The following is a description of a gene set: Genes negatively differentially expressed in cell type: CD8+ T cell upon treatment with cytokine: IL-18 in mouse lymph nodes in vivo. Mouse Gene Set: CUI_T_CELL_CD8_IL18_RESPONSE_DN studied in species Mus musculus from publication Cui A, Huang T, Li S, Ma A, Pérez JL, Sander C, Keskin DB, Wu CJ, Fraenkel E, Hacohen N (PMID 38057668) Cytokines mediate cell-cell communication in the immune system and represent important therapeutic targets. A myriad of studies have highlighted their central role in immune function, yet we lack a global view of the cellular responses of each immune cell type to each cytokine. To address this gap, the authors created the Immune Dictionary, a compendium of single-cell transcriptomic profiles of more than 17 immune cell types in response to each of 86 cytokines (>1,400 cytokine-cell type combinations) in mouse lymph nodes in vivo. A cytokine-centric view of the dictionary revealed that most cytokines induce highly cell-type-specific responses. For example, the inflammatory cytokine interleukin-1β induces distinct gene programmes in almost every cell type. A cell-type-centric view of the dictionary identified more than 66 cytokine-driven cellular polarization states across immune cell types, including previously uncharacterized states such as an interleukin-18-induced polyfunctional natural killer cell state., and this is the list of marker genes: Entrep3, Pdcd4, Srgn, Bcl2, Hmgb2, Tent5a, Cd53, Ssh2, Arl4c, Celf2, Cotl1, S1pr1, Pitpnc1, Stim1, Klhl6, Tsc22d3, Ankrd44, Slamf6 (NCBI Gene Id 80894), Sidt1 (NCBI Gene Id 385649), Btg2, Kmt2e, Tecpr1, Klf3, Tagln2, Ctsw, Vim, Add3, Zfp36l2, Pnrc1, Ets1, Gpr183, Lsp1, Txk, Kif21b, Esyt1, Sell, Mbnl1, Flna (filamin, alpha), Il18r1, Il7r, Gimap6, Fxyd5, Akap13, Arhgap15, Macf1, Cd8b1, Bin2, Epsti1, Ripor2, Arhgdib, Hsd11b1, Myh9, Rgs2, Arhgef18, Atp11b, Cd7, Stk17b, Nkg7, Ctsd, Hcst (NCBI Gene Id 23900), Jak1, Fos, Myl6, S100a6, Itpkb, Tmem50a, Emp3, Atp1b3, Sorl1, Smc4, Cd3g, Arhgap45, Neurl3, Rasgrp2, Ifngr1, Ccl5, Foxp1, Malt1, Gpsm3, Ctla2a, Klrd1, Crip1, Mxd4, Luc7l2, Klf2, Ypel3 (NCBI Gene Id 68930), Arl5c, Tspo, Bin1, Zyx, Laptm5, Txnip, Jakmip1, Cd2, Hdac7, Rgs10, Lef1, Fam78a, Klf6, Acp5, Sp100, Actn1, Adcy7, Ahnak, Cd3e, Peli1, Cd28, Ppp1r15a, Saraf, S100a10, Srpk2, Adgre5, Madd, Selplg